Given this list of marker genes Tpk1, Thtpa, Slc19a2, Slc25a19, Slc19a3, here is a description of the gene set: The chemical reactions and pathways resulting in the formation of thiamine diphosphate, a derivative of thiamine (vitamin B1) which acts as a coenzyme in a range of processes including the Krebs cycle. Mouse Gene Set: GOBP_THIAMINE_DIPHOSPHATE_BIOSYNTHETIC_PROCESS species: Mus musculus